Given this list of marker genes SLC25A37, SLC25A28, SLC30A3, TRPM2, MMGT1, SLC46A3, SLC39A12, SLC11A2, ATP2C2, SLC11A1, SLC30A9, TRPM7, SLC30A8, SLC39A1, SLC39A6, SLC30A10, SLC39A13, SLC39A4, MCOLN1, SLC31A2, ATP7A, SLC40A1, SLC31A1, SLC39A10, TMEM165, ATP7B, SLC39A14, SLC39A9, SLC39A8, SLC30A2, SLC30A4, SLC30A5, TTYH1, SLC30A6, HAMP (NCBI Gene Id 57817), SLC39A11, SLC39A2, SLC30A7, ATP13A1, ATP2C1, SLC39A3, MCOLN2, SLC39A5, SLC30A1, SLC39A7, here is a description of the gene set: Human Gene Set: GOMF_TRANSITION_METAL_ION_TRANSMEMBRANE_TRANSPORTER_ACTIVITY species: Homo sapiens Enables the transfer of transition metal ions from one side of a membrane to the other. A transition metal is an element whose atom has an incomplete d-subshell of extranuclear electrons, or which gives rise to a cation or cations with an incomplete d-subshell. Transition metals often have more than one valency state. Biologically relevant transition metals include vanadium, manganese, iron, copper, cobalt, nickel, molybdenum and silver.